Given this list of marker genes POLR2K, H2BC15, ERCC2, CHD4, H2AC20, GTF2H1, MAPK3, MBD3, H2AC6, HDAC1, CCNH, H2BC11, H2BC13, H2BC12L, TAF1A, EHMT2, H3C15, H2BC12, H2AC14, POLR1G, RRN3, H2AC7, H2AC4, RBBP7, ERCC3, H2BC3, GTF2H2, GTF2H5, TTF1, H2AZ2, POLR1E, POLR2E, MTA1, 45S pre-rRNA gene, H3-3A, TAF1C, POLR1H, POLR2L, GTF2H4, ERCC6, POLR1F, H2AB1, CDK7, MNAT1, MTA2, H2BC5, POLR1A, GATAD2B, GATAD2A, H3C1, POLR1B, H2AX, CBX3 (NCBI Gene Id 82756), TAF1D, TBP, POLR1C, H2AC18, H2BC26, RBBP4, H2BC9, MTA3, MBD2, HDAC2, POLR2H (RNA polymerase II, I and III subunit H), KAT2A, H2BC17, H2BC14, H2AJ, H4C1, H2BC4, UBTF, POLR2F, TAF1B, H2BC21 (NCBI Gene Id 8349), KAT2B, H2BC1 (NCBI Gene Id 255626), POLR1D, CHD3, GTF2H3, here is a description of the gene set: Reactome Pathway: RNA Polymerase I Promoter Clearance part of: RNA Polymerase I Transcription studied in species Homo sapiens Promoter clearance is one of the rate-limiting steps in Polymerase I transcription. This step is composed of three phases, promoter opening, transcription initiation and promoter escape.